Given this list of marker genes Man1c1, Neu3, Calr, Arfgap2, Tubal3, St8sia3, Rps27a, Kdelr3, Neu2, Cnih2, Alg1, Cnih3, Sec24b (SEC24 homolog B, COPII coat complex component), Copb1, Ppp6c, Asgr2 (asialoglycoprotein receptor 2), Alg6, St3gal4, Nagk, Folr1, Gfpt2, Kdelr2, St8sia4, Amdhd2 (NCBI Gene Id 245847), Tubb6, Cog7, Ubb, Nsf, Psmc1 (NCBI Gene Id 19179), Mgat1, Dynll1, St6gal2, Tubb4a, Copb2, Man2a1, Copg2, Areg, Engase, St6galnac1, Uso1 (USO1 vesicle docking factor), Npl, Cmas, Nans, Alg8, B4galt6, Mgat4c, Gorasp1, Nudt14, Chst8, Tmed10, Manea, Sec31b, St3gal5, Bet1, Scfd1 (NCBI Gene Id 76983), Tuba1c (tubulin, alpha 1C), Sptbn2, Sec16b, Col7a1, Tuba3b, Tuba1a, Vcp, Kdelr1, Golga2, Cog8, B4galnt2, Ins1, Actr10, F8 (coagulation factor VIII), Asgr1, Sec31a (NCBI Gene Id 69162), Neu4, Trappc9, Fut8, Tuba4a, Rab1a, Rab1b, Tubb4b, Lman1, Renbp, Derl1, Glt28d2, Copg1, Dolk, Dctn6, Tuba8, St6galnac3, Arcn1, Sec24a, Arf5, Fuom, Slc35c1, Tmed3, Lman2l, St8sia5, St3gal3, Ins2 (NCBI Gene Id 16334), Sptbn4, Ctsc, Dync1li2, Tmed9, Man1a, Neu1, St6galnac6, Arf1, St3gal2, St6galnac4, Nanp, Lman1l, St6galnac2, Ank1, Tgfa, Tuba1b, Sec24d, St8sia2, Dctn1, Cga, Alg12, Tubb2b, Trappc5, Gmppa, Amfr, Fpgt, Gfus, Cd55, Gnpnat1, Gmppb, Actr1a, here is a description of the gene set: This event has been computationally inferred from an event that has been demonstrated in another species.<p>The inference is based on the homology mapping from PANTHER. Briefly, reactions for which all involved PhysicalEntities (in input, output and catalyst) have a mapped orthologue/paralogue (for complexes at least 75% of components must have a mapping) are inferred to the other species. studied in species Mus musculus part of: Post-translational protein modification Reactome Pathway: Asparagine N-linked glycosylation electronically inferred by orthology from the curated human pathway